Given this list of marker genes PPARG, VEZF1, TNNT2, PDGFRB, TAF1A, DSP, PSEN2, NEXN, ALG9, SYNE1, CAVIN1, RNU7-1, ABCC9, HAND2, SYNE2 (NCBI Gene Id 26075), RAF1, SLC29A3, SPRTN, RPL3L, AGPAT2, TMPO, FLNA, LAMA4, DSG2, DOLK, MTX2, POLR3A, ATP6V1A, ADAR, GATAD1, VCL, AKT2, MYBPC3, B4GALT7, IGF1R, POMP, TCAP, FUCA1, LMOD2, FBN1, MYH6, ACTC1, DES, TPM1, PSEN1, KRAS (NCBI Gene Id 3845), FKTN, SCN5A, ANKRD1, LMNA, TWIST2, KCNJ6, MYH7, BAG3, TNNC1, PCYT1A, LIPE, TXNRD2, FHL2, ALG3, TREX1, CAP2 (NCBI Gene Id 10486), LSM11, RNASEH2C, ATP6V0A2, LDB3, PMM2, GRM7, EMD, CAV1, CRYAB, PSMB4, TNNI3, BANF1, FHL1, SDHA, ACTB, TMEM43, RNASEH2B, CSRP3, COL3A1, OTULIN, ATP6V1E1, SLC25A24 (NCBI Gene Id 92093), RBM28, GET3, SAMHD1, DNASE2, DPAGT1, PRDM16, LMNB2, RBM20, TAFAZZIN, POLD1, WRN, PLAAT3, DMD, FOS, PSMB8, MYPN, PSMG2, DDOST, CLMP, SGCD, PIK3R1, PLIN1, ACTN2, ALB, TTN, CIDEC, ZMPSTE24, FGFR1, PIK3CA, RNASEH2A, IFIH1, ADRA2A (adrenoceptor alpha 2A), BAG5, BSCL2, JPH2 (junctophilin 2), AKT1, VPS4A, MFN2, PLN, LMF1, PPCS, here is a description of the gene set: Human Gene Set: HP_LIPODYSTROPHY Degenerative changes of the fat tissue. Lipodystrophy studied in species Homo sapiens